Given this list of marker genes TGS1, NCOA6, NRIP1, SIRT1, RAI1, NCOR1, RORB, NCOA2, MEF2D, CRTC2, NCOA1, TBL1X, MEF2C, ATF2, NPAS2, CREBBP, EP300, BMAL1, CHD9, HELZ2, HDAC3, CRTC1, PPARGC1A, CREB1, TBL1XR1, CARM1, NR1D1, CRTC3, RORA, CLOCK, RORC, RXRA, SMARCD3, PPARA, MED1, here is a description of the gene set: Reactome Pathway: Expression of BMAL (ARNTL), CLOCK, and NPAS2 part of: Circadian clock studied in species Homo sapiens BMAL1 (ARNTL), CLOCK, and NPAS2, which acts redundantly with CLOCK, are key activators of diurnal circadian gene expression. Their expression is positively regulated by the Retinoid-related orphan receptors RORA, RORB, and RORC and negatively regulated by the nuclear receptor NR1D1 (REV-ERBA), all of which complete for the same ROR responsive elements (RRE, RORE) (inferred from mouse homologs in Ueda et al. 2002, Guilaumond et al. 2005) in the BMAL1 promoter (inferred from the mouse homolog in Sato et al. 2004, Akashi and Takumi 2005, Guillaumond et al. 2005, Takeda et al. 2012) and CLOCK promoter (inferred from mouse homologs in Lau et al. 2004, Takeda et al. 2012). ROR nuclear receptors bind oxysterols while NR1D1 binds heme, thus providing potential links with metabolism. <br>ROR nuclear receptors recruit coactivators of transcription such as EP300 (p300), PPARGC1A (PGC1A) (inferred from mouse homologs in Lau et al. 2004), and NRIP1 to activate transcription by RNA polymerase II. In contrast, heme-bound NR1D1 recruits the corepressor NCOR1, and the histone deacetylase HDAC3 to repress transcription. <br>The genes encoding RORA, RORC, and NR1D1 regulate BMAL1 and CLOCK and are regulated by BMAL1 and CLOCK, thereby constituting a secondary loop in the mammalian circadian clock.